The following is a description of a gene set: from publication Schaeffer EM, Marchionni L, Huang Z, Simons B, Blackman A, Yu W, Parmigiani G, Berman DM (PMID 18794802) Early prostate development genes (up-regulated at 6 hr dihydrotestosterone) which are also up-regulated in high grade prostatic intraepithelial neoplasia (PIN) vs invasive cancer. Cancer cells differentiate along specific lineages that largely determine their clinical and biologic behavior. Distinct cancer phenotypes from different cells and organs likely result from unique gene expression repertoires established in the embryo and maintained after malignant transformation. We used comprehensive gene expression analysis to examine this concept in the prostate, an organ with a tractable developmental program and a high propensity for cancer. We focused on gene expression in the murine prostate rudiment at three time points during the first 48 h of exposure to androgen, which initiates proliferation and invasion of prostate epithelial buds into surrounding urogenital sinus mesenchyme. Here, we show that androgen exposure regulates genes previously implicated in prostate carcinogenesis comprising pathways for the phosphatase and tensin homolog (PTEN), fibroblast growth factor (FGF)/mitogen-activated protein kinase (MAPK), and Wnt signaling along with cellular programs regulating such 'hallmarks' of cancer as angiogenesis, apoptosis, migration and proliferation. We found statistically significant evidence for novel androgen-induced gene regulation events that establish and/or maintain prostate cell fate. These include modulation of gene expression through microRNAs, expression of specific transcription factors, and regulation of their predicted targets. By querying public gene expression databases from other tissues, we found that rather than generally characterizing androgen exposure or epithelial budding, the early prostate development program more closely resembles the program for human prostate cancer. Most importantly, early androgen-regulated genes and functional themes associated with prostate development were highly enriched in contrasts between increasingly lethal forms of prostate cancer, confirming a 'reactivation' of embryonic pathways for proliferation and invasion in prostate cancer progression. Among the genes with the most significant links to the development and cancer, we highlight coordinate induction of the transcription factor Sox9 and suppression of the proapoptotic phospholipid-binding protein Annexin A1 that link early prostate development to early prostate carcinogenesis. These results credential early prostate development as a reliable and valid model system for the investigation of genes and pathways that drive prostate cancer. Human Gene Set: SCHAEFFER_PROSTATE_DEVELOPMENT_AND_CANCER_BOX2_UP studied in species Mus musculus, and this is the list of marker genes: LDB2, NREP, SPARCL1, FBLN1, CSNK1A1, CALR